Given this list of marker genes NQO2, RPS19, MCM8, POLD1, KCNAB2 (potassium voltage-gated channel subfamily A regulatory beta subunit 2), C7orf50, CTSA, POLA2, ANP32E, ELP1, MXD4, RAB11FIP5, MESD, PDCL, SLC50A1, KCTD13, MKNK1, RPP21, SPICE1, VDAC2, IDH3B, SARS1 (NCBI Gene Id 6301), MCTS1, LAPTM5, OTUD6B, SLC39A6, PALD1, HAUS1, CETN3, ENTPD4, CPSF4, C1GALT1, LRSAM1, NDUFV3, RNF141, MRPS12, ABCG1, ABCB7, XRCC1, ATG101, ZNF708, MYC, HMOX1, ZBTB14, NBN, ATG12, CARS2, PRPSAP2, AMDHD2, FRRS1, GNPTG, PRKCI, PPARG, TAF5 (TATA-box binding protein associated factor 5), BAG4, NUP50, MAF1, ARFGEF2, DTYMK, GAMT, TMEM263, ARHGDIB, CPEB2, DENND2D, PDE8B, RHOV, S100A6, SRPK2, LAGE3, CRYGD, ARHGAP15, BOLA1 (bolA family member 1), NTPCR, CNOT9, FAM162A (family with sequence similarity 162 member A), ANKMY2, BCL2 (NCBI Gene Id 596), G3BP1, SKI, SERTM1, GOLIM4, COQ9, RAB11FIP2, E2F1, TBC1D14, CTSV, CENPB, UQCC6, LRRC8D, BACH1, SAC3D1 (NCBI Gene Id 29901), CEP164, ATP5MC1, WDR6, TMEM208, EBPL, IL16, MBP, PIK3CG, COX8A, NUDT21, ATE1, GK5, EFCAB11, SLC39A12, PLPBP, KANSL2, DUT, THUMPD2, EIF4A2, LRATD2, ALAD, PRKAR1A (NCBI Gene Id 5573), HABP4, TXNDC15, ABHD17A, MRPS33, HSPA14, USE1, CGRRF1, CMC2, MLF1, ATP5F1C, STMN1, NUDC, RIPK3, TSEN2, GGACT, DPY30, PLEKHB2, MFSD12, GSK3B, PDPR, ATP7A, DHCR7, RNF157, CRTAP, SIKE1, TBC1D7, TBC1D2, CHMP6, TEC, CTNS, RCAN3, ZNF622, NEK9, RPL17, NEIL3, THYN1, SACM1L, GSTO1, GMPR2, ERH, MTX2, B3GLCT, MRPL49, DHRS1, AHCY, SLC66A1, ANAPC7, DHTKD1, ATRX, ITGAM, ATP6AP1, ID1, SEPHS2, GTF2IRD1, ABCB4, PDE8A, MCM4 (minichromosome maintenance complex component 4), VPS45, MCFD2, WDR11, PSPH, BTBD3, NAA50, PTGR2, MRPS17, NME1, ARMT1, ITGB5, RFC4, CMTM3, FHIP2A (NCBI Gene Id 57700), ABCB10, NUDT6, RAD51, SEC11A, ING2, GLUD1, BLTP3B, TEP1, ATP6V0D2, THAP4, FARP2, MRPS35, RPS27L, ATAD5, CARD19, LBR, here is a description of the gene set: The innate immune system is a two-edged sword; it is absolutely required for host defense against infection, but if left uncontrolled can trigger a plethora of inflammatory diseases. Here we used systems biology approaches to predict and validate a gene regulatory network involving a dynamic interplay between the transcription factors NF-κB, C/EBPδ, and ATF3 that controls inflammatory responses. We mathematically modeled transcriptional regulation of Il6 and Cebpd genes and experimentally validated the prediction that the combination of an initiator (NF-κB), an amplifier (C/EBPδ) and an attenuator (ATF3) forms a regulatory circuit that discriminates between transient and persistent Toll-like receptor 4-induced signals. Our results suggest a mechanism that enables the innate immune system to detect the duration of infection and to respond appropriately. Human Gene Set: GSE14769_40MIN_VS_360MIN_LPS_BMDM_UP from publication Litvak V, Ramsey SA, Rust AG, Zak DE, Kennedy KA, Lampano AE, Nykter M, Shmulevich I, Aderem A (PMID 19270711) studied in species Homo sapiens Genes up-regulated in comparison of macrophage cells stimulated with LPS (TLR4 agonist) for 40 min versus macrophage cells stimulated with LPS (TLR4 agonist) for 360 min.